The following is a description of a gene set: Reactome Pathway: Biosynthesis of the N-glycan precursor (dolichol lipid-linked oligosaccharide, LLO) and transfer to a nascent protein part of: Asparagine N-linked glycosylation studied in species Homo sapiens N-linked glycosylation commences with the 14-step synthesis of a dolichol lipid-linked oligosaccharide (LLO) consisting of 14 sugars (2 core GlcNAcs, 9 mannoses and 3 terminal GlcNAcs). This pathway is highly conserved in eukaryotes, and a closely related pathway is found in many eubacteria and Archaea. Mutations in the genes associated with N-glycan precursor synthesis lead to a diverse group of disorders collectively known as Congenital Disorders of Glycosylation (type I and II). The phenotypes of these disorders reflect the important role that N-glycosylation has during development, controlling the folding and the properties of proteins in the secretory pathway, and proteins that mediate cell-to-cell interactions or timing of development., and this is the list of marker genes: PMM2, DPM1, ST8SIA1, DHDDS, GMPPB, ST8SIA5, ALG12, ST3GAL1, PMM1, ALG10B, DPM2, FCSK, ALG2, NUS1, ST6GAL2, ST8SIA2, ALG13 (NCBI Gene Id 79868), NEU2, ST6GALNAC6, ST6GAL1, DPM3, DOLPP1 (NCBI Gene Id 89888), FUOM, SRD5A3, ST3GAL4, NEU3, ALG14, RENBP, ST6GALNAC2, SLC35A1, NEU4, RFT1, ST8SIA4, GNPNAT1, ST6GALNAC1, ST8SIA3, MPDU1, AMDHD2, ST8SIA6, ALG8, ALG11, ALG6, ALG3, ALG1, ST6GALNAC3, GMDS, GFUS, GLB1, SLC35C1, MVD, ST3GAL6, ST6GALNAC5, DOLK, FPGT, ALG10, CMAS, GFPT2, ALG9, GNE, MPI, ST6GALNAC4, ST3GAL3, GMPPA, NANP, NPL, ST3GAL5, GFPT1, NEU1, PGM3, UAP1, NAGK, HK1, SLC17A5, NUDT14, CTSA, NANS, ALG5, DHRSX, DPAGT1, ST3GAL2